Given this list of marker genes TRAM1, LINC01023, ACACA, LMNA, SURF4, LINC02585, NKIRAS2, SETD9 (NCBI Gene Id 133383), ANKRD18CP, ARL2BP, ZNF497-AS1, ZNF572, DDX51, TOX4, SETD7, FJX1 (NCBI Gene Id 24147), TUFT1, CDKN2AIPNL, ATG9A, COA1, NEK4, TYW1B, MACROD1, MDC1, AK9, POLR2J3, GLI1, RAB2A, TNPO2, SLC6A6, EFCAB14, GCDH, EN2, THG1L, RASGRP2, ZNF619, TMED4, SMIM2-AS1, STAG2, SNRPD1, ATP5MJ, SPIDR, ZNF501, DMTN, COPA, EIF1, SHLD2, PARL, SEH1L, FUNDC1 (FUN14 domain containing 1), CNST, PPP3R1, TBCCD1, C14orf119, RANBP9, PPT1, UBXN6, ATP5MC2, ADRM1, ELAC2, RNF216P1, ENSG00000293341, BCS1L, SH2B1, DBP, PCBP1, ZNF621, SCAMP3, NOL7, UBE2Q2, HIGD1AP5, MALAT1, MED4 (mediator complex subunit 4), F11R, GLI4, UBE2J2 (NCBI Gene Id 55482), BZW2, TBP, STKLD1, LRRC8B, CCDC115, SH3GL1, DPH7, HBEGF, COQ2, RPL31, UBE2Q2P13, TMPOP2, PCMTD1P3, GABBR1, MRPS2, SCARNA2, COMMD5 (NCBI Gene Id 90980), ZNF768, ECH1, WDR6, FAM228B, NPC1, GSS, ZNF16, EN2-DT, SIN3A, MRPS10, DNAJC16, HARS1, ILK, PSCA, ZNF445, RCAN1, PLBD1, TRIM36, DIDO1, ACVR2A, ZNF594-DT (ZNF594 divergent transcript), STT3A, ZFP62, WDR75, MDP1, TOMM20L-DT, NLE1, IBA57-DT, RNFT2, MIR22HG, SHKBP1, CUEDC2, C18orf54 (NCBI Gene Id 162681), MIB2, SLC9A8, SEPTIN2, MTERF1, NCL, TNRC18, CASP9 (NCBI Gene Id 842), FLNC, PSMD1, RMC1, COPS7A, RPS27L (NCBI Gene Id 51065, ribosomal protein S27 like), POLR3C, COL1A1, MIR9-1HG, SMIM12, XRN1, PGBD2, RNVU1-30, PCMTD2, CELF3, ARK2N, ENSG00000253986, ZNF554, SCARNA16, SYS1-DBNDD2, YBX1, EIF5A, SLC30A6, CERNA3, BRWD3, SEMA4C, CILK1, TIMM8B, SMPD2, MRPS31, YTHDF2, ATOSB, SLC9A1, ZFYVE21, VPS4A, FIRRM, WDR7, POLR2J, ZKSCAN3, ZKSCAN4, ZNF692, DAZAP2, ZNF707, SNORA50C, POMGNT2, ZNF142, NR2C1, SOX21, POLQ, COPS9, LINC01391, MIR4665, RNF227, IRF1, ZNF22-AS1, TMEM97, ZCCHC24, MRTFA, PPIL6, ARVCF (ARVCF delta catenin family member), METTL25, RWDD3-DT, PGBD1, STOML2, MRPS33, OTUD7A, GOSR1, ZNF623, ENSG00000217455, ZFP91, ZCWPW1, CTDSP1, THA1P (NCBI Gene Id 390816), C15orf40, MIR1915, EIF2S1, PFDN5, SF3A3, RRP8, THOC1, ZNF670, TOMM22-DT, MIR4638, BTK, SPTBN1, RPSAP31, ATP6V1D, POM121C, LARP1, CCT7, RPS17, CCDC59, KATNBL1, MRPL14, YPEL1, TP53I13, SAAL1, SSBP4, MPHOSPH6-DT, IER5 (NCBI Gene Id 51278), RN7SL521P, ASH2L (NCBI Gene Id 9070), S100A10, EPCIP-AS1, PCBP1-AS1, TBX18, ZNF629, ZC3H10, KIF1C, LGALS3BP, EXD1, ARID2, HNRNPD-DT, WNT11, LINC01301, STK35, RAD1, STK31, ZFP3-DT, LINC00863, ZBED9-AS1, EGLN1P1, KDM1A, SNHG25, UBE2Q2P16, AXL (NCBI Gene Id 558), TCF25, AGFG1 (ArfGAP with FG repeats 1), ADPRS, DEPDC5, HNRNPAB, CELSR2, ETV6, CERS2, PIGO, ZSCAN23, AKAP9, CLK3, PSMD6, POLG2 (DNA polymerase gamma 2, accessory subunit), RAB3A, CYTH2, RPL30, ZSCAN2-AS1, POMZP3, PPP1R7, RINT1, ADPRM, SNORD55, ZNF787, SUGT1-DT, CPD, ZNF250, SNORD104, SNORA78, DNAI4, DUSP12, ZSCAN26, MED13L, LINC01285, CMIP, RPS8, BMP4, HIBCH, PPP2R3B, ZNF7, POLR1HASP, UQCRC2, SNX5, UBE2Q2P12, ZFTRAF1 (zinc finger TRAF-type containing 1), RPL36A-HNRNPH2, MEAF6, FNTA, CGN, ZNF425, ZSCAN25, HNRNPK, ZNF23, MAPK7, RNA5SP473, PIANP, SEM1, AHDC1, BAGE2, RAB11FIP1, RPS3A, THOC5, HOOK2, ZNF202, CCDC65, ETF1, SNORD54, PCNP, CTTNBP2, RPS14, CFAP73, B9D1, ZKSCAN5, LLGL1, DNAJB11, RPL11, MPP2, RNVU1-28 (NCBI Gene Id 124904616), LRRC59, FNIP1, ZNF696, ZKSCAN8, ALG13, PITPNA, MGAT4A, NIP7 (NCBI Gene Id 51388), HROB, SLC39A9, ARHGAP17, SLC30A6-DT, NUP160, LINC00265, GFUS, IFT46, PTTG1IP, SSRP1, KIFC2, HDAC6, TRIM52, SNRPE, ZNF502, GFRA1, PISD, GDPGP1, DDB1, ZNF398, RPL32P27, NPW, UBE2Z, ZNF3, R3HCC1, HECTD1, TLN1, RFWD3, CCDC9, ERCC1, RPS20, LINC02896, SUGT1, FZD9, TRMT2A, ARRDC3-AS1, SNAP47, CDIPTOSP, HECW1, DRAIC, SPHK2, ANKRD20A18P, TBC1D12, BBIP1, FAM89B, TAF1B, RAB2B, SPRYD7, C11orf96, NUTM2A-AS1, SEPHS1, ZNF789, SAMD4B, GLUD1, COA7 (cytochrome c oxidase assembly factor 7), COX7A2, EGR1, STX10, TMPOP1, SESN1, KMT2A, METAP2, PAK4, ZNF35, DET1, LRRC47, CCDC90B, NCOR2, TBPL1, SCO1 (NCBI Gene Id 6341), SEC14L1, DAAM1, FRS3, RPL10, UBAC2, UQCR11, RPL23AP77, ZSCAN12, SRRM3, EIF5B, RNFT1-DT, ZNF148, MEGF9, ATXN3, GOT2, MIR4530, RBM17, PLBD1-AS1, MEPCE, TRIM41, MIR4519, ZSCAN30, FOXO3, GCFC2 (GC-rich sequence DNA-binding factor 2), SF3B6, EPB41L5, ING2, MNT, AP3B2, RBM48, HYAL2, RABGGTA, SEC1P, RBM25, EEF1AKMT2, DEF8, IMMT, WWTR1, LINC01385, DMPK, CDKN2C, ETHE1, BCL7B, ZNF672, EBF1, ANKRD46, MFSD4A, TNKS1BP1, MOSPD1, MARS1, RNU5A-1, ZNF594, RNPS1 (NCBI Gene Id 10921), AARS2, PARN (poly(A)-specific ribonuclease), SCAND3, RPL36A, RNU5B-1, ANKMY2, NECAP2, ZNF19, ANP32B, RPL18, PARS2, NIFK-AS1, CELSR3, ZNF44, UST, MEGF8, ZNF197, ACTB, GAPDH, PSMB1, SERGEF, TUFM, RPL37A, TRIM7, CIT, BYSL, JRK, MAGEA4, PNPLA6, SOCS2, ZIC2, CLASP1, PSMB3, TCF4, CREB3, RRN3, GOLPH3, ATG101, MED20, RWDD3, ZNF692-DT, PIERCE1, ABCD4, ABCA1, POLR2C, CISD1, GLO1, ENSG00000266976, PIK3R1, PPM1L-DT, MECR, TXNL1, ZKSCAN7-AS1, STARD6, DNAJB1, UGGT1, DHX8, POLR2A, SLC35A1, BRSK2, REX1BD, TRIM52-AS1, TMEM63B, OSBPL7, GLUD2, ERRFI1, GAPDH-DT, PRPF18, CERS6, SNX15 (NCBI Gene Id 29907), LPXN, TIMM10, NRG3, MIRLET7BHG, NUTM2B-AS1, MTURN, MIR6853, RASGRP1, VAV2, CDIPT, TAB1, SYS1, ERRFI1-DT, UBE2Q2P6 (UBE2Q2 pseudogene 6), ZSCAN9, UPP2, YLPM1, NCBP1, RNVU1-15, TRIP11, FIG4, TOMM22, FLT1, NCBP3, BRIX1, SLC25A10, COPS8, RNFT1, RNF216, ZCCHC4, EXTL3-AS1, ZNF394, EIF6, AIMP2, ZBTB4, DDX46, INCA1, RANBP1, NXT2, XRCC3, APTX, BRD7, CRLF1 (NCBI Gene Id 9244), AP1S2, ACVR1, TFB2M, DNAJC7, CEP57L1 (NCBI Gene Id 353369), CRTAP, PAICS, COPS4, SLC27A1, NCSTN, PPAT, HNRNPD, GPATCH4, NRP1, ZNF687 (NCBI Gene Id 57592), WTAP, SLC27A3, HDAC2-AS2, WWTR1-AS1, LSR, COMMD10, DYSF, CIPC, PMS2, LBHD1, RPL37A-DT, TKFC, NOC4L, PRADC1, RAB40C, CEP120, SBDSP1, CNOT8, SCAND2P, G6PD, MEIS1-AS3 (MEIS1 antisense RNA 3), CSH2, PTCH1, GNAS, RBM45, FAM89A, TRAF4, SHOC2, PEX12, PCBP2, HCG15, RPS2, SMARCD1, DDX18, FAM133B, SNHG17, ANKRD18DP, GOLPH3-DT, IKBKG, CAMK1, TMEM267, ANKZF1, ZNF598 (zinc finger protein 598, E3 ubiquitin ligase), FBRSL1, ASB6, SATB2, FBRS, THOC1-DT, CDKN2A, MEF2D, RO60, SNHG20, FBXL5, CEBPA-DT, ERH, RPL7L1, SNORD118, CRADD-AS1, ZNF670-ZNF695, RAB6A, MCIDAS, FIS1 (NCBI Gene Id 51024), ACTR6, PSMB7, MIR762HG, RNF115, ATL2, ARL14EP, TTC5, USP40, SEPTIN1, CDCA8, RPL36, RTBDN, TSTD2, RPS7, GH2, SDHD, HDLBP, CHPF2, CLNS1A, IMP4, ARPC1A, TINF2, SRP68, CNTRL, CENPBD1P, KDM3B, ARRDC3, PRPSAP1, PAXBP1, PIK3R4, HES2, LIPE-AS1, KBTBD8, MGME1, LEISA1, LACTB2-AS1, PPM1L, ANXA2, ZNF496, ZSCAN21, SEC24A, TWSG1-DT, TWSG1, ENDOG, MADCAM1, MIR1915HG, ESYT1, METTL18, FAM83C-AS1, ENHO, TXNDC9, SNHG9, MEIS2, PPIA, ZNF271P, FAM200A, SLC45A1, ZNF252P, EGR2, GMEB1, ZNF311, GPR35, GSN, PEX5, RNU5F-1, PCYOX1, UCHL5, GGA1, MPHOSPH6, SNHG11, BFAR, HIF1AN, ZFP3, CIB1, POLR1H, ZKSCAN1, MAGI1, RAG1, COPS8-DT, NHP2, COG8, HARS2, NAV2, ZNF48, DUSP3, MIPEP, VAPA, IBA57, EOLA2-DT, ARHGEF1, EIF3G, CACYBP, PTMA, PROS1, ZSCAN16, UQCC3, REEP4, TCF7L1-IT1, RPS9, PARD3B, ZFP91-CNTF, SCYL3, CHP1, THUMPD1P1, TAF10, MRPL12, CDKL5, FAM13C, VASP, IER2, MDM4, SDR42E1, JAGN1, ANKRD19P, MIS18BP1, TRIO, ZNF251, NDUFB7, ING2-DT, VRTN, PEX1, TRAF6, here is a description of the gene set: Genes containing one or more binding sites for (SNIP1) in their promoter regions (TSS -1000,+100 bp) as identified by GTRD version 20.06 ChIP-seq harmonization. studied in species Homo sapiens Human Gene Set: SNIP1_TARGET_GENES from publication Yevshin I, Sharipov R, Kolmykov S, Kondrakhin Y, Kolpakov F (PMID 30445619)